Given this list of marker genes Ndufv3, Eif1, Sar1a, Ube2s, Ergic3, Pnrc1, Cd81, Cybb, Rrbp1, Ubb, Rab2a, Pim1, Lmna, Eloc, Anxa5, Atp5mk, Eif5b, Odc1, Sec11c, Rabac1, Smarca5, Ptges3, Tuba4a, Manf, Rbm25, Ell2, Edem1, Arf4, Bsg, Ghitm, Cyba, Lmbrd1, Spcs2 (signal peptidase complex subunit 2 homolog (S. cerevisiae)), Sfr1, Tbcb, Lmnb1 (lamin B1), Cacna1s (NCBI Gene Id 98698), Mtdh, Slc25a3, S100a11, Dpm3, Hsp90b1, H2az1, Ubxn4, Ndufb11, Nop58, Xbp1, Stat3, Tmem160, Aldoa, Prdx1, Pfdn2 (NCBI Gene Id 18637), Adgre5, Tuba1b, Sod1, Crip1, Calm1, Srsf11, Prrc2c, Gnl3, Ywhaz, Pdia6, Psmb8, Psap, Fgl2, Dnajc3, Txndc5, Sh3glb1, Atp2b1, Rel, 1810037I17Rik, AW112010, Dnaja1, Ptprc, Arpc3, Tpm4, Eef1d, Atf4, Klf10, Napsa, Cdk2ap2, Ddx5, Rbm39, Selenos, Dynll1 (NCBI Gene Id 56455), Tagln2, H13, Tubb4b, Bcl2a1b, Rer1, Pdia3, Fth1, Ndfip1, Tubb2a, Gapdh, Cd44, Fkbp2, Sp140l2, Ddx6, Prpf4b, Nfil3, Tmem258, Psmb9, Gpx4, Psme2, Iqgap1, Atp5mj, Skil, Mzb1, Map1lc3a, Sp140l1, Cox6c, Slbp, Mpc2, Irf1, Pttg1, Strap, Elob, Atp5f1d, Ldha, Ezr (NCBI Gene Id 97496), Prdx6, Tspo, Emp3, Txn1, Pld4, Cycs, Vps28 (NCBI Gene Id 68286), Oaz1, H2-T23 (NCBI Gene Id 15040), Srrm2, Traf1, Ube2j1, BC031181, Nop56, Itm2c (integral membrane protein 2C), Dcn, Selenok, Uqcrb, Hspa4 (heat shock protein 4), G3bp2, Itm2b, Sdf2l1, Srgn, Kmt2e, Zfand6, Txnip, Ahnak, Tcf4, Gadd45b, Srsf7, Tuba1a, Sbds, H2-Eb1, Cst3, Plac8, Ubc, Baz1a, Itgb7, Vim, Jchain, Ppp1r2, Malat1, Tmbim6, Hspa5, Emd, Litaf, Cdkn1a, Got1, Ankrd33b, Rheb, Prr13, Bcl2a1d, Vcp, Fos, Id2, Fxyd5, B2m, Ndufa4, Ly6a, Ddx24, Kras, Tmed10, Sat1, Sertad1, Plek (NCBI Gene Id 69998), Tomm7, Cd9, H2-Q4, Prdx2 (peroxiredoxin 2), Sp140, Clic4, Sub1, Cyp4f18, Crem, H2-K1, Hnrnpu, Erp44, Dnajc7, Jund, Fosb, Derl1, Rsrp1, Pfdn5, Man1a (mannosidase 1, alpha), Lgals1, Lgals3, Ccnl1, Dad1, Dnajb6, S100a6, Rtn3, Tuba1c, Slc3a2, Kdm6b, Gstp1, Ndufa1, H2-D1, Cd86, here is a description of the gene set: Mouse Gene Set: TABULA_MURIS_SENIS_LIMB_MUSCLE_B_CELL_AGEING from publication Tabula Muris Consortium (PMID 32669714) species: Mus musculus